Given this list of marker genes DUSP12, NUDT5, TXNRD2, NEIL3, CENPB, ANAPC15, KIAA0040, CCKAR, KCTD9, BAX, OTUB2, IER3IP1, NDC1, XIST (NCBI Gene Id 7503), FAAP24, E2F8, ITGA6, WDR4, LHFPL6, BCAT1, ARHGAP19, SLC11A2, DPP8, ABCF2, SLC7A5, KIF18A, TACC3, CKS2, RBKS, CARHSP1 (calcium regulated heat stable protein 1), MATCAP2, PPP2R2D, DNAJC21, COX19, TNFRSF19, BMAL1, WSB2, HDAC8, CPM, CD79A, C19orf38, PRG2, CENPM, PTCD2, ZFPM1, DUSP19, LGR5, BUB1B, MTHFD2, ENPP6, TMEM255A, CCSAP, BST1, AAR2, CARS1, SPIB, TMEM26, CDCA8, SAPCD1, MAX, ANAPC10, FASTKD2, OAF, SPAG5, CDC20, SRPK3, KLHL32, SCD, RBM19, ZMAT5, ARF5, CDADC1, KLHL25, BACH2, STK11, DEPDC1, DLGAP5, RRAGD, TBL2, MTHFD1L, CPLX2, CAPSL, TDP1, TTC4, UBE2C (NCBI Gene Id 11065), C19orf53, UBE2L3, IRS1, C1orf116, CBY1, CCND3, SKA2, SMC1A, TASP1 (NCBI Gene Id 55617), DARS2, SPC24, MED8, CKAP5 (cytoskeleton associated protein 5), MAOA, ZCCHC17, ARMC6, ENOX1, C1orf53, MTMR14 (NCBI Gene Id 64419), LRR1, MUTYH, NCLN, IL33, F13A1, FARS2, IGLL1, ZNHIT1, ALDH1B1, TRIB2, RNF214, GADD45A (NCBI Gene Id 1647), BRF1, INTS10, SEH1L, RPIA, CDC45, WLS, WDR55, ESPL1, DDC, PLSCR1, LEF1, EME1, TRIM2, VIRMA, TWSG1 (NCBI Gene Id 57045), MRPL47, COX16, TTK, MELK, SGK1, PDSS2, CNNM4, FXN, GLE1, RRAS2, ARL2, GPSM2, NUDT15, GPR155, CENPW, ASCC1 (activating signal cointegrator 1 complex subunit 1), NCAPH, SMARCA4, AARSD1, TSFM, GEN1, MEGF9, PPME1, ESCO2, TSSC4, FCRLA, TUFM, MRPL58, ZW10, SPATA24, SNRNP27 (NCBI Gene Id 11017), MSRB1, KNSTRN, ACP5 (acid phosphatase 5, tartrate resistant), TIMM10B, TUBB2B, KIF2C, APOO, NAT9, APBA3, ZNF428, SH3YL1, DFFA, SUSD1, HTATIP2, CLYBL (NCBI Gene Id 171425), MIS18BP1, PIDD1, PNKP, SKA1 (NCBI Gene Id 220134), FAM221A, CD38, PTRHD1, PDCD1, TENT5C, LACTB2, H1-4 (H1.4 linker histone, cluster member), EFCAB2, MASTL, C1orf50, SLC15A3, CKAP2L, PPP1R35, PREP, POLH, NRARP, IGLC7, SDR39U1, JUN, here is a description of the gene set: Primary HBE cells were stimulated with IL-22 and IL-17, and gene expression was studied using an Affymetrix platform microarray, in order to investigate which genes may be upregulated or downregulated in response to these cytokines. Of particular interest was the host defense genes such as antimicrobial peptides, which have been shown to be upregulated by IL-22 and IL-17 in skin keratinocytes. species: Homo sapiens from publication Aujla SJ, Chan YR, Zheng M, Fei M, Askew DJ, Pociask DA, Reinhart TA, McAllister F, Edeal J, Gaus K, Husain S, Kreindler JL, Dubin PJ, Pilewski JM, Myerburg MM, Mason CA, Iwakura Y, Kolls JK (PMID 18264110) Genes up-regulated in primary bronchial epithelial cells: control versus stimulated with IL17A and IL22. Human Gene Set: GSE10240_CTRL_VS_IL17_AND_IL22_STIM_PRIMARY_BRONCHIAL_EPITHELIAL_CELLS_UP